The following is a description of a gene set: studied in species Homo sapiens Parkin-ubiquitin proteasomal system pathway Human Gene Set: WP_PARKINUBIQUITIN_PROTEASOMAL_SYSTEM_PATHWAY, and this is the list of marker genes: PSMD10, PSMD12, TUBA3C, HSPA2, HSPA1A, CASP8, CASP1, PSMD1, SIAH2, CASK, TUBB1, PSMD11, TUBA4A, TUBB, HSPA9, TUBA1A, PSMD7, UBE2G1, TUBA3D, PSMC4, HSPA4, SNCAIP, PSMD3, UBE2G2, SIAH1, PSMD14, PSMD4, TUBA8, TUBA3E, PSMC3, TUBB4A, TUBB4B, STUB1, HSPA1L, PSMD5 (proteasome 26S subunit, non-ATPase 5), UBE2L3, TUBB3, TUBAL3, SNCA, PSMC5, HSPA5, TUBA4B, TUBB2A, TUBB6, PSMD2, CCNE1, SEPTIN5, PRKN, GPR37, TUBB8, TUBA1C, PSMC2 (proteasome 26S subunit, ATPase 2), UBE2J1, CUL1, FBXW7, UBE2L6, HSPA14, PSMD13, HSPA1B, HSPA8, TUBB2B, PSMC6 (proteasome 26S subunit, ATPase 6), PSMC1, UBE2J2, TUBA1B, PSMD9, PSMD8 (proteasome 26S subunit, non-ATPase 8), RNF19A, UBA1, HSPA6, PSMD6